The following is a description of a gene set: species: Homo sapiens Cytosine methylation Human Gene Set: WP_CYTOSINE_METHYLATION, and this is the list of marker genes: IDH2, TDG, IDH1, MBD3, TET1, TET2, MECP2, DNMT1 (NCBI Gene Id 1786)